Given this list of marker genes Lin7a, Six1, Colq, Lin7b, Agrn, Musk, Pdzd11, Gsk3b, Lin7c, Six4, Mycbp2, here is a description of the gene set: Mouse Gene Set: GOBP_REGULATION_OF_SYNAPTIC_ASSEMBLY_AT_NEUROMUSCULAR_JUNCTION species: Mus musculus Any process that modulates the frequency, rate or extent of synaptic assembly at neuromuscular junctions.